The following is a description of a gene set: A filamentous, cage-like assembly on the nuclear face of the nuclear pore complex (NPC). In S. cerevisiae, Mlp1p and Mlp2p are two major components of the NPC nuclear basket. In vertebrates, Tpr is a major component. Human Gene Set: GOCC_NUCLEAR_PORE_NUCLEAR_BASKET studied in species Homo sapiens, and this is the list of marker genes: PCID2, NUP35, MAD1L1, TPR, MCM3AP, RANBP2, ENY2, ZC3HC1, CETN2, NUP98, CETN3, MAD2L1, NUP153